Given this list of marker genes Ppat, Gad2, Got2 (glutamatic-oxaloacetic transaminase 2, mitochondrial), Aldh4a1, Arg1, Gls, Atp2b4, Nos1, Nos3, Oat, Adhfe1, Dao, Gls2, Fah, Prodh, Arg2, Got1, Ddah1, Nos2, Glud1, Prodh2, Asrgl1, Gad1, here is a description of the gene set: Mouse Gene Set: GOBP_GLUTAMINE_FAMILY_AMINO_ACID_CATABOLIC_PROCESS The chemical reactions and pathways resulting in the breakdown of amino acids of the glutamine family, comprising arginine, glutamate, glutamine and proline. studied in species Mus musculus